The following is a description of a gene set: Human Gene Set: GOBP_CELL_MORPHOGENESIS_INVOLVED_IN_NEURON_DIFFERENTIATION The process in which the structures of a neuron are generated and organized. This process occurs while the initially relatively unspecialized cell is acquiring the specialized features of a neuron. studied in species Homo sapiens, and this is the list of marker genes: YTHDF1, MAP6, LZTS1, ULK2, MAP2K1, CNTN4, MARK2, KIFBP, PTPRZ1, GFRA3, TRPC5, ENAH, CDH4, BBS1, NDEL1, CXCL12, NOVA2, DBN1, ANAPC2, STXBP1, CELSR3, LHFPL5, SYNGAP1, LRP8, KIF13B, TBR1, TWF2, MYCBP2, CDHR1, GLI2, NUMBL, NTRK3, PLXND1, POTEJ, CDK5R2 (cyclin dependent kinase 5 regulatory subunit 2), KIAA1755, RTN4, S100A6, EFNA1, CHRNB2, SCN11A, CFAP418, FGF13, SEMA3B, SLITRK6, MAPT (NCBI Gene Id 8152), NECTIN1, TUBB3, APLP2, SEMA3E, CD2AP, BCL11B, KIF5A, SPAST, CFL1, NCAM1 (NCBI Gene Id 4684), MAP3K13, TRIOBP, RAB10, TMEM106B, SHANK1, PALLD, LHX4, VAX1, CUL7, TBC1D24, NOTCH2, NKX2-8, EDN1, BRSK1, KIF5B, PLXNB2, TBCE, ECE1, CNP, RAB3A, LPAR3, TCTN1, PLXNA4, IFRD1, DOCK7, CELSR2, DOCK10, SPG11, PDZD7, ALCAM, SEMA5B, BMPR2, SPG21, PTPRJ (NCBI Gene Id 5795), AMIGO1, MACF1, CNTNAP1, GRXCR2, CUX2, NGFR, ACTBL2, PRKCQ, LRRK2, EPHB6, RAB21, FLRT3, RND2, ROBO1, FZD4, ERBB2, SLC1A3, SCRIB, NEXN, SLITRK1, SEMA4G, PTN, NR2E1 (nuclear receptor subfamily 2 group E member 1), ITPKA, EGR2, PREX2, ABI1, KIDINS220, SEMA3G, EDNRA, OPHN1, SLC30A1, LGI1, KIF21A, ELAVL4, RAC1, ACTB, RGMA, ROBO3, NGF, VANGL2, ATP8A2, SRCIN1, VLDLR, CRPPA, WNT7B, SLC11A2, SKIL, SMO, ARX, ARMCX5-GPRASP2, SLIT2 (slit guidance ligand 2), CYFIP2, UST, RELN, STK25, EMB, COL25A1 (collagen type XXV alpha 1 chain), SEMA6D, PHACTR1, CTTN, ATOH1, RAB8A, PARD6B, ZDHHC15, STRC, PAX6, CDKL3, BARHL2, DHX36, CYFIP1, PLEKHG4, S100B, EDN3, LHX3, ATL1, DTNBP1, PRKCA, FZD3, RTN4R, MCF2, NOTCH3, NTN4 (NCBI Gene Id 95736), WNT7A, SLC25A46, GPRASP3, POTEE, NLGN3, FBXO45, EPHB3, WDPCP, SEMA4F (NCBI Gene Id 9408), NEFL, SULT4A1, NRP2, PHOX2B (NCBI Gene Id 8929), METRN, DAB1, CNTN1, CHN1, GOLGA4, LAMA2, PLS1, FYN, B4GALT6, PTK2, BMPR1B, MAP1A, ZFYVE27, BCL2, LAMB2, ABI3, TLX2, ADCY10, NRDC, APBB1, KIF1A, POU4F2, CCKAR, EFNB3, MINK1, ARC, LMO4, SDC2, LHX9 (NCBI Gene Id 56956), ADCY1, RYK, DSCAM, NOG, NFIB, ABL1, CLASP2, GDI1, DLG4, CC2D1A, GATA3, GDF7, PARD3, HEXA, TANC2, NELL2, UNC5D, UNC5C, STMN1, CABP4, VASP, WNT3, REST, ARHGEF28, FLOT1, EFNA3, KNDC1, TRIO, KEL, ISLR2, NR4A2, NKX2-1, PLPPR4, ARHGAP35, TTL, AFG3L2, NUMB, NRCAM, DVL1, SHOX2 (NCBI Gene Id 6474), ITGA4, FARP1 (NCBI Gene Id 10160), RPS6KA5, VEGFA, BRSK2, GORASP1, AUTS2, EFNB2, LMX1A, PRICKLE1, PGRMC1, WASL, CREB1, DSCAML1, MYO7A, SZT2, NTRK2, SPART, PTPN11, IL1RAPL1, NLGN1, CLRN2, NPTN, B3GNT2, LHX1, PLA2G10, SIN3A, GPRIN3, NEO1, SLITRK5, ETV1, ATP7A, NPR2, HDAC6, MAP2K2, SEMA5A, SLITRK2, ABITRAM, VAX2, FBXW8, DCDC2, TIAM2, FN1, ADAM17, NKX6-1 (NK6 homeobox 1), C9orf72, KALRN, LLGL1, TSKU, ADNP, PPP3CA, SLIT1, LIMK1, MYOT, HPRT1, GSK3B, IGF2BP1, KIAA0319, IST1, USH1C, EPHB1, NIN, LZTS3, SMAD4, SEMA3F, SEMA3C, MAG, TUBB2B, TRAK1 (NCBI Gene Id 22906), PLXNA3, HECW2 (NCBI Gene Id 57520), SARM1, VCL, PTPRM (protein tyrosine phosphatase receptor type M), NEDD4, ABLIM1, NDN (NCBI Gene Id 4692), SEMA7A, APP, NTN3, SHH, ARTN, PTPRD, ACTL8, BOC, UNC5B, PAK1, SCN1B, TRIM46, CSF1R, ROBO4, SRF, EVX1, EVL, LGR6, PAK3, DRGX, PLEKHG4B, POU4F1, BMP7, ARHGAP44, PPFIA2, TNIK, SEMA3A, RNF6, NDP (NCBI Gene Id 4693), EFNA5, FEZF1, ID2, RPL24, FOXG1, SEMA3D, RET, PQBP1, IGSF9, ADGRB3 (NCBI Gene Id 9664), DPYSL5, NR4A3, TOP2B, MFSD2A, APOE, EDN2, GRXCR1, PITPNA, RUFY3, NFASC, CDK5, PTEN, MAP1S, ARHGAP33, CRABP2 (NCBI Gene Id 1382), ADARB1, DNM2, HECW1, TRAK2, APLP1, NTNG1, GBX1, OLFM1, RAC3, PTK7, NTRK1, ITGB1, ZNF365, POU4F3, PAX2, HES1, WDR47, ULK1, SPP1, EPHA10, SLIT3 (slit guidance ligand 3), FSTL4, RAPGEF2, ACTG1, SEMA6A, LHX2, CNTN2, NEDD4L, DLX5, FEZF2, POTEKP, WNT3A, ATG16L1, C12orf57, CHL1, CDH23, NRXN3, ANK3, SMURF1, LRRC4C, RERE, PTCH1, DISC1, SLC9A6, SEMA6C, EPHA4, FEZ2, PRDM8, NFATC4, TNR, ZEB2, PRKG1, CAPRIN2, TBCD, CHRNA7, MEGF8, ANKRD24, BDNF, EPHA7, EFNB1, MEF2A, RAP2A, ATOH7, KIFC2, SS18L1, CDH11, ROBO2, EFNA2, BCL11A, CDC42, SPTBN4, MAP2, UNK, BAIAP2, NGEF, GLI3, CHRNA3, FLRT2, NOTCH1, SEMA4C, EPHA8, SEMA4B, COBL, EEF2K, ANKRD27, PSEN1, DCLK1, MYH10, STK11, PPP3CB, ISL2, BSG, DCC, ARHGEF25, FAT3, PCDHAC2, OBSL1, SLITRK3, CNTN5 (contactin 5), PAFAH1B1, PARP6, CCK, TGFB2, PLXNC1, EPHB2, CLRN1, ABI2, ARK2C, NRP1, POU3F2, NEUROG3, UNC5A, OTX2, FGF8, NSMF, NPTX1, KIF5C, PTPRH, MATN2, NHERF1, POTEI, OR10A4, WNT5A, KLF7, EXT1, TNFRSF12A, RB1, FEZ1, TPRN, NRXN1, SKOR2, FOXB1, CAMK2B, MEF2C, PLXNB1, EFNA4, L1CAM, CUX1, CNTN6, BRAF, SIAH1, SHANK3, YWHAH, SEMA4A, HOXA2, DIP2A, MAPK8IP2, UCHL1, LRP4, PAK2, STAU2, ARHGAP4, USP33, MAP1B, SSNA1, TECTA, TTC8, FOXD1, SIPA1L1, SEMA6B, PICALM, DIP2B, CTNND2, PDLIM5, ARHGEF40, ANOS1, ISL1, FGFR2, DAG1, ZDHHC17 (zinc finger DHHC-type palmitoyltransferase 17), MT3, CTNNA2, EPHA3, GBX2, DRAXIN, GAP43, MYPN, PTPRS, CDK5R1, SOS1, SLITRK4, DRD2, NEFH, TRPC6, PLXNB3, SEMA4D, EPHA6, SHTN1, POTEF, B4GALT5, CAPRIN1, LYPLA2, WHRN, CDKL5, TIAM1, APBB2, RAPH1 (Ras association (RalGDS/AF-6) and pleckstrin homology domains 1), TAOK2, CDH1, XK, TRPV2, PTPRO, NTN1, NTNG2, B4GAT1, CHODL, BTBD3, SOD1, TPBG, GDNF, TNN (tenascin N), THY1, ADGRB1, SEC24B, HMCN2, EPHA5, USP9X